Given this list of marker genes AGT, AGTR1, CORIN, DRD2, NPPB, NPR1, EDN1 (endothelin 1), SPX, here is a description of the gene set: Any process that modulates the amount of sodium excreted in urine over a unit of time. Human Gene Set: GOBP_REGULATION_OF_RENAL_SODIUM_EXCRETION studied in species Homo sapiens